Given this list of marker genes BSCL2, TREX1, KYNU, NADK2, GLYCTK, POLG, TSPOAP1, SUCLA2, HTRA1, TH, WDR45, TBCE (tubulin folding cofactor E), here is a description of the gene set: studied in species Homo sapiens Progressive encephalopathy Human Gene Set: HP_PROGRESSIVE_ENCEPHALOPATHY